Given this list of marker genes CLEC10A, LGALS2, KLRC1, LGALS9, KLRC3, ASGR2, FCN1, CD22, GCKR, CLEC3A, CLEC2B, OLR1, REG1B, LGALS3, GFPT2, APCS, CLC, KLRK1, SIGLEC5, LGALS1, SFTPA1, CHIT1, LMAN2, LGALS4, SELP, FCER2, CD69, NCAN, THBD, CD72, SELL, SFTPD, CLEC3B, MRC1, ASGR1, FCN2, here is a description of the gene set: Cell adhesion. species: Homo sapiens Human Gene Set: MODULE_410